The following is a description of a gene set: Human Gene Set: chr6q24 studied in species Homo sapiens, and this is the list of marker genes: LTV1, LINC01625, SAMD5, PLAGL1, RNU1-33P, PEX3, RNA5SP222, CCDC28A-AS1, ADGB, RAB32 (RAB32, member RAS oncogene family), PHACTR2-AS1, RPS3AP24, EPM2A-DT, HIVEP2-DT, HEBP2, MRPL42P3, ATP5PBP6, SHPRH, ENSG00000226249, YAP1P1, SMIM28, ADGB-DT, TPT1P4, KATNBL1P6, UTRN, ECT2L, AIG1, RNU6-906P, VTA1, CITED2, RNU6-1222P, CYP51A1P3, RNA5SP221, REPS1, STXBP5-AS1, NMBR, RNA5SP220, FBXO30, PHACTR2, MARCKSL1P2, RPS3AP23, RN7SKP106, TXLNB, ABRACL, EPM2A, HIVEP2, NHSL1-AS1, LINC02919, ZC2HC1B, GRM1, SF3B5, FUNDC2P3, ENSG00000226571, NHSL1, ACKR4P1 (ACKR4 pseudogene 1), GJE1, MIR3668, VDAC1P8, STXBP5 (syntaxin binding protein 5), STX11, FUCA2, ENSG00000236366, HECA, PARLP2, LINC02941 (NCBI Gene Id 100507477), SASH1, LUADT1, MTCH1P1, ADAT2, TUBB8P2, LINC01277, CCDC28A, ADGRG6, MIR3145, FILNC1, NMBR-AS1, MIR4465, HYMAI